Given this list of marker genes Rad51ap1, Arfrp1, Cbx6, Aplf, Lrr1, Kctd20, C230035I16Rik, Trp53bp1, Glra1, Tcof1, Slc5a3, Uggt1, Nsa2 (NCBI Gene Id 80423), Arl8b, Golgb1, Sinhcaf, Cfap74, Ipo8, Bicdl1, Gpalpp1, Ipo4, Stk11ip, Gm22748, Smad7, mt-Tq, Faap24, Eeig1, Tent5c, Uvrag, Pcnx3 (NCBI Gene Id 56836), 2500002B13Rik, Cct8, Bud13, Azin1, Anks3, Fam227a, Dyrk1b, Myo19 (myosin XIX), Csnk1g1, Tmem267, Ankhd1, Stam2, Thbs3, Sox21os1, Ell3, Bbln, Dusp13b, Ube4b, Anapc11, Sugp1, Nr3c1 (NCBI Gene Id 14815), Pmm1, Gpr137c, Hivep2, Grik3, Stk38, Gpatch4, Abcf1, Iqcg, Gm26504, B130034C11Rik, Mrm1, Trub1, Nipa2, Syndig1l, Appbp2os, Pias3, Zfyve19, 4933405L10Rik, Gar1, Pcna, Ppp6r1, Rfx1 (NCBI Gene Id 19724), Nek5, 4930535L15Rik, Cimap2, Gprc5c, Lca5l (NCBI Gene Id 385668), Trip12, Eaf2, Dalrd3, Nsun6, mt-Rnr1, Dnajc6, 1700088E04Rik, Akap10, Nudt6, Kat2b, Trmt13, Vta1, Synj1, Ppm1d, Skp2, Tesk2, Smyd5, Tom1, Sumf1, Zbed5, 9530051G07Rik, Uqcc3, Gm16853, Ogdh, Rnf10, Psma7, Tob1, Btbd19, Nek2, Cfap298, Dars2, Chchd3, 1700084E18Rik, Gm15564, Hspa5, D6Wsu163e, Tsc22d2, 1700041G16Rik, Yrdc, Kif9, Rela (NCBI Gene Id 19697), A230056P14Rik, Mir7b, Rab3gap1, Gm7285, Drap1, Atad3aos, Tcp11l2, Rnf166, Chchd7, Nufip1 (nuclear FMR1 interacting protein 1), Pdgfa, Tubd1, Spaca9, Elf2, Ect2, Brd10, Flad1, Tmem59, Rad9b, Rtcb, Wdr90, Mms19, Ccnb2, BC005624, Palld, Rer1, Grm2, Ppp4r3b, Wdr74 (NCBI Gene Id 107071), Cggbp1, Btbd10, Bnc2, Chtop, Plekhm1, Xbp1, Kmt2c, Ppp1r14b, Arl16, Syce2, Wdr76, Sec16a, Enkd1, Dynll1, Eme1, Zbtb40, Trafd1, Dcun1d1, Nup43, Ubtd1, Vwa2, Gm11346, Bbc3, Foxj1, Rpl30, Wbp11, Arhgap21, Ctu2, Fastk, Gm15545, Ube2r2, Rbpj, Ighv8-5, Ttk, Cog7, LTO1, Ccne1, St8sia3 (ST8 alpha-N-acetyl-neuraminide alpha-2,8-sialyltransferase 3), Sptbn4, Fbxl13, Ccdc146, Bin3, Tcf24, mt-Tp, Tcta, C130046K22Rik, Ghdc, Mre11a, Glyr1, Atp6v0d1, Ercc4, Mmgt2 (membrane magnesium transporter 2), Dcun1d4, Dync2i1, Cep76, Ccdc77, Kdm5a, Sass6, 5330413P13Rik, Polr1has, Ift80, Tmem126b, Eno4, Ubxn10, Cfap69, Sco1, Rnd2, mt-Tt, Gm31728, Fam78a, Cyb5b, 6330403L08Rik, Cyb5d2, Ddx46, Golga5 (golgin A5), Usp2, Pop5, Slc30a8, Plag1, Gm13228, Relb, Zfp184, Zfp24, Raf1 (NCBI Gene Id 76876), Chchd4, Nmbr, Gm10961, Dennd2b, Vti1b, Ulk4, Cdc42bpa, Proser1, Gm2449, Trip4, mt-Tw, Ak8 (adenylate kinase 8), Oxsm, AV099323, Fbxo36, Lin52, Tpp2, Pcgf1, Babam2, Pfn2, Rundc1, Ccdc92b (NCBI Gene Id 432582), Nppb, E230015B07Rik, Kcnb1, Pprc1, Gm12359, Cops2 (NCBI Gene Id 98909), Tmem198, Phf19, Rundc3a, Fbxl20, Cfap57, Trerf1, Mcm7, Tada2b, Gm11399, Prr3, Gm20544, Ccs, Gpank1, Cdca5, Syf2, Ubxn11, Txndc16, Rgl1, Med9os, Gprin1, 4930583K01Rik, Hpca, Nme7, Hadhb, Atp6v0b, Otud4, Akap1, Cyb5r4, Usp36, Klhl18, Dlgap3, Crip2, Gpatch11, Chrnb2, Slf2, Xpo5, Spout1, mt-Ti, Cby1, Pex19, Psmd5, Cox4i1, Slc39a3, Fbf1, Smim5, Shb, Psmc2, Gm20404, Aatf, Ube2q2, Cep170, Herpud1, Cdc42ep4, Ptpn4, 1110059E24Rik, 3110070M22Rik, Ctns, 9930004E17Rik, Mir6236, Morn1, Tagln2, Tbcc, Gmppa, Gm22107, Serpinb6a, Vamp8, Slc12a4, Rpusd2, Dner, Mapk3, S100pbp, Dusp18, Gpn3, Anapc2, AI467606, Gm13421, Gm9530, Mrpl27, Phf21a, Ptdss2, mt-Ta, Hnrnpc, Zfp768, Cdc42se1, 1110065P20Rik, Trappc8, Myg1, mt-Tf, Adprm, Casc3, Rbks, Mcfd2, Tmem9b, 1700125G22Rik, Gm9245, Mid1, Ctbp2, Zzef1, Nr2c2ap, Kitl (NCBI Gene Id 17311), Tmcc1, Shld2, Ankrd12, Dnajc17, Spcs1, Cenpl, Med23, Klc2, Gfm2, Hk2 (hexokinase 2), Hmgn1, Gm15704, Arrdc4, Zgpat, Smdt1, Polr3g, Grin1, Coa8, Spata6, Mtx1, Smim19, Ntaq1, Sys1, Pdzd2, Erf, Tmco3, Unc50, Ptges3l, 1700086P04Rik, Tspan17, 2810402E24Rik, Rsph4a, Syncrip, Tbc1d10b, Lsm1, Duxf1, 2610005L07Rik, Rsph3b, Gnl1, mt-Cytb, Adprs, Odf2, Htr5a, Gm13033 (predicted gene 13033), Afg2a, Polr2f, Mir8120 (NCBI Gene Id 102465905), Ndufb5, Mks1, Glt8d1, Tef, Cep95, mt-Tc, Marchf10 (membrane associated ring-CH-type finger 10), Yif1a, Mospd3, Gm15579, Adissp, Psmb2, Chka, Slc39a11, Ostf1, Rnf19b, 1700007L15Rik, Gdf6, Fam222a, Mpc1 (NCBI Gene Id 70697), Skap2, Kmt2d, Ncoa2, Rbmxl1, Mfap1a, Gm38250, Gm15706, Nfat5, 4930509H03Rik, 1700064M15Rik, Armc9, Arhgap42, Npdc1, 0610009E02Rik, Fbxl18, Tmem263, Aurkaip1, Gm8357, Atat1, Gm10222, Mageh1, Faf1, Tsr3, Dnajc5, 4930408O17Rik, Cnpy3, Stx11, Gm2479, Hars1, Pgap3, Map4k2, Zbtb11os1, Cacna2d4, Sfi1, Wdr73, Arhgap11a, Gm14963, 2810414N06Rik, Nhlrc3, Ubxn6, Chpf, Gm10766, mt-Nd2, Crkl, Efhb, Cfap300, Cspp1, Csnk2b, Cmtr2, Mettl4, Zfyve1, Lrig2 (NCBI Gene Id 99941), Ccdc170, Zfp747, Cnot6l, Tprn, Cep162, Prim2, Gm8580, Spata31e2, Gm24641, Gmfg, Nsd3, Kpna6, Cab39, Pax5, Sltm, Fhl4, mt-Rnr2, Camkmt, Bag4, Mblac2, Lrrc8a, Otud7b, Hk1, Phb2, Lhx3, mt-Ty, mt-Tn, Rrp12, Tmeff1, Vkorc1, Dyrk2, Gm37450, Catsperd, Etohd2, Cfap58, Rlf, Vps51, 9430038I01Rik, Rdh13, Kif2c, Prkar1b, Luzp1, Hk1os, 1700086L19Rik, Fosb, Asb1, Zfp688, Tonsl, Hsdl1, Cox8c, Rps6ka5, Six6, Adarb1, 5730480H06Rik, Ebna1bp2, 1700001G17Rik, Stx12, Pdgfc, Prdm1, Pdcd6, Apaf1, 8430429K09Rik, Tmem237, Lrrc75a, Samd8, Ankrd42, Prdm9, Dbp, Ctdspl, Nmrk1, Ndufaf7, Fez2, Dync1i2, Armc7, Snapc4, Armc10, Orai1, Srp72, Rnf24, Stard7, Usp20, Acox3, Klf10, Emg1, Fbxw7, Lonp1, Pigp, Gli2, Ccdc18, Galk2, Dok2, Gm26608, Pfkfb2, Triobp, 4931440P22Rik, Med9, 1110018N20Rik, Fau-ps2, Lrrc56, Coa5, Yars1, 4930467K11Rik (NCBI Gene Id 74928), Hint3, Rpl35a, Ripk1, Gm15952, Epg5, mt-Tv, Ikbip, Zfp655, Blzf1, AI837181, Cdc20, Lrtm2, Sdccag8, Psme3, Fnbp1, D16Ertd472e (NCBI Gene Id 69342), Ctr9, Dnajc16, Dap3 (death associated protein 3), Ccdc30, Htra2, Cacng3, E030030I06Rik, H2-T11-ps, 4930429F24Rik, Map3k11, Gm25541, Cdc25a, Sort1, Abhd17b (NCBI Gene Id 70566), Cars1, Timm10 (NCBI Gene Id 30059), Mms22l, Mapk8ip2, Pyroxd1, Cfap119, Dlec1, Scrt1, Hsd17b4, 0610039K10Rik, Tfip11, Zfpl1, Gm15627, Tceanc2, Pbk, Vps45, Ccdc96, 4921536K21Rik, Castor2, Pla2g2c, 4632428C04Rik, Mosmo, Cep89, Anapc7, mt-Tm, Gm17690, Gm12474, Prepl, Ak9, Zhx3, Mtnap1, here is a description of the gene set: from publication Yevshin I, Sharipov R, Kolmykov S, Kondrakhin Y, Kolpakov F (PMID 30445619) Mouse Gene Set: ND5_UNIPROT_A0A023J5X2_UNREVIEWED_TARGET_GENES species: Mus musculus